Given this list of marker genes HTRA3, AOX1, PHKA1 (phosphorylase kinase regulatory subunit alpha 1), FKBP7, CALU, DBN1, CFL2, P3H1, SEC23A, NAAA, ITGB1BP1, IGFBP4, TGFBR2, MRC2, ADGRA2, GAMT, PCOLCE, CCL15, FCGRT, AP1S2, WNK1, MRAS, NRP2, EHBP1L1, ST8SIA4, EMP3, FN1, IKBIP, SNX9, ZEB1, LOXL3, PKD1, FKBP9 (NCBI Gene Id 90212), LRP1, LOXL1, DAB2, F13A1, PRRX2, SACS, SNX20, CFP, CDH13, RAP1B, TIMP2, VIM, OLFM1, CLEC4A (C-type lectin domain family 4 member A), NR2F1, MCUB, SELENON, EFEMP2, JDP2, NFATC1, ANGPTL2, FCGR2B, GLIPR1, ITGA5, PVR (PVR cell adhesion molecule), SPTBN1, GPR85, PLAT, PLXND1, C1QTNF6, GZMH (granzyme H), RGS18, PRRX1, OTUD7B, ADPRH, TJAP1, B3GNT9, NEK9, RIPOR1, MRC1 (NCBI Gene Id 4360), CHRNA1 (NCBI Gene Id 1134), CYSLTR1, FAM167B, RRAD, WAS, APBB1, CCDC102A, FXYD5, TTYH2, POFUT2, RNF157, OSR1, IL18R1 (NCBI Gene Id 8809), AXL, GNB4, ENO3, EPB41L2, LTC4S, SEMA7A, DDR2, HHEX, LPAR1, APBB2, VSIG4, LSP1, CSF1R, PLEKHA3, SNX6, SCARA3, HSPG2, CELF4, CSGALNACT2, NRROS, VEGFC, TSPAN4, HLX, MATN2, DOK1, MXRA8, CCL2, NBL1, PHLDB1, ANKRD1, FOLR2, C11orf24 (NCBI Gene Id 53838), SH3GLB1, MEDAG, ARL6IP5, ST3GAL2, PLA2G15, DNM1 (dynamin 1), TRAF1 (NCBI Gene Id 7185), CCR2, LAMB1, GPR34, CSF1, CFH, STK17B, ZFPM2, PDGFRA, MARVELD1, SPI1, FLNC, S100A4, DCN, ARHGEF40, here is a description of the gene set: studied in species Mus musculus Genes that are highly expressed in mammary tumors of epithelial-mesenchymal transition (EMT) histology. Human breast cancer has been characterized by extensive transcriptional heterogeneity, with dominant patterns reflected in the intrinsic subtypes. Mouse models of breast cancer also have heterogeneous transcriptomes and we noted that specific histological subtypes were associated with particular subsets. We hypothesized that unique sets of genes define each tumor histological type across mouse models of breast cancer. Using mouse models that contained both gene expression data and expert pathologist classification of tumor histology on a sample by sample basis, we predicted and validated gene expression signatures for Papillary, EMT, Microacinar and other histological subtypes. These signatures predict known histological events across murine breast cancer models and identify counterparts of mouse mammary tumor types in subtypes of human breast cancer. Importantly, the EMT, Adenomyoepithelial, and Solid signatures were predictive of clinical events in human breast cancer. In addition, a pan-cancer comparison revealed that the histological signatures were active in a variety of human cancers such as lung, oral, and esophageal squamous tumors. Finally, the differentiation status and transcriptional activity implicit within these signatures was identified. These data reveal that within tumor histology groups are unique gene expression profiles of differentiation and pathway activity that stretch well beyond the transgenic initiating events and that have clear applicability to human cancers. As a result, our work provides a predictive resource and insights into possible mechanisms that govern tumor heterogeneity. Human Gene Set: HOLLERN_EMT_BREAST_TUMOR_UP from publication Hollern DP, Swiatnicki MR, Andrechek ER (PMID 29346386)